The following is a description of a gene set: Human Gene Set: FOURATI_BLOOD_TWINRIX_AGE_25_83YO_RESPONDERS_VS_POOR_RESPONDERS_0DY_DN from publication Fourati S, Cristescu R, Loboda A, Talla A, Filali A, Railkar R, Schaeffer AK, Favre D, Gagnon D, Peretz Y, Wang IM, Beals CR, Casimiro DR, Carayannopoulos LN, Sékaly RP (PMID 26742691) species: Homo sapiens Genes down-regulated in blood responders vs poor responders in adults (25-83) (responders) after exposure to Twinrix, time point 0D Aging is associated with hyporesponse to vaccination, whose mechanisms remain unclear. In this study hepatitis B virus (HBV)-naive older adults received three vaccines, including one against HBV. Here we show, using transcriptional and cytometric profiling of whole blood collected before vaccination, that heightened expression of genes that augment B-cell responses and higher memory B-cell frequencies correlate with stronger responses to HBV vaccine. In contrast, higher levels of inflammatory response transcripts and increased frequencies of pro-inflammatory innate cells correlate with weaker responses to this vaccine. Increased numbers of erythrocytes and the haem-induced response also correlate with poor response to the HBV vaccine. A transcriptomics-based pre-vaccination predictor of response to HBV vaccine is built and validated in distinct sets of older adults. This moderately accurate (area under the curve ~65%) but robust signature is supported by flow cytometry and cytokine profiling. This study is the first that identifies baseline predictors and mechanisms of response to the HBV vaccine., and this is the list of marker genes: CRCP, DDI1, KPNA6, CDCA8, RNF112, CYP2C8, PARP9, TPP1, ASCL2, NSD3, ITGA2B, KXD1, LOXL4, NUDT16-DT (NCBI Gene Id 339874), FKBP9, TBCD, TCERG1L, HS2ST1, REEP3, ZFHX3, OASL, TNNI2, FMNL1-DT, BEND7, CAMP, CD14, TPSD1, MT2A, GNAT1, KDM5D, TTTY7B, CAVIN3, HNMT, NUP93, KCNQ1, PGBD2, GNG4, LINC01503, IFI44L (NCBI Gene Id 10964), WNT5B, CEP63, AGFG1, RBMY1A1, TTLL3 (NCBI Gene Id 26140), WWC2 (WW and C2 domain containing 2), VPS53, TNFSF10, SCD, TXLNGY, ATP8B3, DGKG, LINC01168, LRRC75B, VCX3A, CDH17, GFER, CRISP3, TNPO1 (NCBI Gene Id 3842), KIF18B, TRIM21, HPR, IFI16, PIWIL2, VCX, AAMDC, TTTY1, PPARA, HSPA1B, TONSL, HOXB-AS3, FGF18, MAP2K6, TGIF2LX, ANXA8L1, CIMAP1B, CTTNBP2NL, FAM114A1, PLB1, ELOVL3, VEGFC, BEAN1, CFAP46, NUMA1, LINGO2, ADGRF3, DCLRE1C, NETO1, PTX3, ALYREF, PLAAT5, FSTL3, PDE12, TPM1, ABHD2, STBD1, RBM47, RECK, MED29, ZMYND10, DMXL2, RRBP1, TDRD9, GNA14, GLB1L3, TTTY1B, NOTCH2NLA, IFIT3, SLC35A2, RFTN1, MICAL2, SRRM2, NISCH, COL2A1, LOXL3, RABL6, ETV6, CTSB, RHOU, PROB1, H2BW1, DYNLT2B, RCOR3, DLEU7, CORO2A, HPX, B4GALNT2, CTSG, YWHAE, DDX6, SH3RF1, KCNJ2, TRPM2, ZNF516, RO60, CGAS, SLPI, IFI27 (interferon alpha inducible protein 27), STMN1, ZFP91-CNTF, GPR84, NCLN, FXYD6, LYPD4, IKBKG, EPHB2, GPD2, PAQR5, PCLO, LDLRAD3, FGG, SP110, DLGAP5 (DLG associated protein 5), SAP30, FGD4, PRR11, ITGB3 (NCBI Gene Id 3690), WBP2NL, SCG3, POMC, PYGB, ATF7, TPCN2, NT5DC4, HBZ, KRT73, CCDC149 (coiled-coil domain containing 149), NEK3 (NIMA related kinase 3), ST8SIA5, AGRN, TTTY14, NCBP3, AKR1B15, SENP5, FCER1G, H4C9 (NCBI Gene Id 8294), SNORD62B, AFMID, XKRY, RBPJ, TTTY2, CTNNBIP1, MX1, COL6A2, NPRL3, PGPEP1, GAB1, ASRGL1, EPS8L1, ZBP1, RNASE3, KAT6A, TCERG1, TMEM8B, CABIN1, SHROOM3, TKT, ANOS1, CDT1, CD163 (NCBI Gene Id 9332), MYB, C22orf23, PRRC2C, CCNB2, LRATD1, SLC46A1, SIRT6, ROCK2, AGTPBP1, TNFSF13B, ITGA9, UBR4, DAGLB, LRRC71 (leucine rich repeat containing 71), BAK1, HEATR3, OAS1, LATS2, SNAP23, CTNNA1, SLC32A1, FCAR, SLC17A5, ZFP91, TJP2, LINC00901, SERINC2, DLG5, PGA4, MMP11, ANKRD11, SPATA31C1, URB1, MEAK7, MET, H2AZ2, PML, CASP10, PPP4R2, FGD6, EVX1, LINC01270, PRKD1, GRK3, DDX3Y, RPL7L1, NTNG2, CENPE, TSBP1, ISG15, NBPF10, LGALS12, AZU1 (azurocidin 1), OSGIN1, DEFA4, UNC93B1, LINC00588, CAPN1 (calpain 1), SLC39A7, CAPG, SCRG1, SPATA31C2, MEG3, UQCRQ, GNA11, ACADS, CYRIA, AIF1, ARF5, CFAP73 (cilia and flagella associated protein 73), UNKL, GLB1L, HCN2, VCAN, FCN1, ABL2, SCRT1, LRSAM1, FOLR2, SLC6A5, CUX1, SCARB2, CASQ1, TPSAB1, EMC9, FAM95B1, LGALS3BP, HP, CILK1, SLC22A18AS, LRRK1, PRR27, COL11A2, SYT5, JPH4, TLK2 (NCBI Gene Id 11011), HTRA1, NUMBL, TRIM14, C3AR1, NFIC, SLC27A4 (NCBI Gene Id 9176), FAM3B, CDC42BPA, RPS4Y1, ARSA, STK36, MAP3K20, RBMY1B, MX2, SLC9B1, PCA3, NEURL1, NR2F2, TRAPPC14, ZNF704, RERE, SNORD9, SF3B1, UBE2C, VHL, OR52E8, TADA2A, SPIRE2, CLTCL1, XKRYP7, H4C1, MMP8, CD300E, BOD1L1, HPGDS, NHSL1-AS1, TNRC18, KIF9, RBMY1E, MEX3C, TEP1, H3C13, IL34, ADAM17, TSHZ3, TM7SF3 (NCBI Gene Id 51768), NBPF15, ZEB2, MAPK14, EPB41L1-AS1, ADAMTSL2, PSORS1C3, MPO, OPLAH, SCCPDH, BPI, DEFA1 (NCBI Gene Id 504182), CFAP119, H3C15, GPN2, TGIF2LY, NR6A1, NUDT3, PIK3AP1, TPMT, ATP5MF, PLSCR1, TBC1D16, FUOM, RRAGD, PALLD, COG4, BTN3A1 (NCBI Gene Id 11119), MTCL1, RNF208 (ring finger protein 208), PAQR6, BAZ2B, LFNG, CSNK1D, POLR3K, IRF7, THBS1, NIBAN1, SPATA41, PFKFB3, ANGPT1, CYTOR, HLA-DRB4, P2RY2, GPR151, ATF6, PLCE1, APP, IGF1R, REC8, NECTIN1, CD109, SPATA2L, AGMO, CRHBP, LINC02649, HLA-A, HLA-DQA1, PNPLA1, PLIN5, HGF, RNF32-DT, ABCC6, RPS4Y2, MMP19, RALGPS2-AS1, ADGRE2, OR6C1, TNNT3, CD63, ERBB2, OTX1, CHIT1, LINC00900, NRARP, ZNF106, SIN3B, NUDT12, RSPH9, MYCL, SLC36A1, PTPRZ1, FUCA2, CAD, RING1, SLC5A12, LRMDA, PPFIA1, COL4A1 (collagen type IV alpha 1 chain), VCX3B, DHRS4L2, TP53I3, MIR4435-2HG, APOL6, NMNAT2, IFI44 (NCBI Gene Id 10561), DNAH12, BBS7, S100A4, PCBD2, ABCB5, MROH7-TTC4, KIAA2013, TYMP, BPESC1, KCTD20, USF1, GCM1, NUBP2, H3C14, CHCHD2, SORT1, KLK10, KLHL10, KAAG1, PAWR, EXOSC3, ART1, TLE6, HEATR5A, ARPC4-TTLL3, KIF5B, NAAA, EPB41L3, NDUFA4L2, STK11IP, GPR107, EPB41L4A, ARL11, CEACAM8, MKI67, OLAH, APLP2, GLMP, HELZ2 (helicase with zinc finger 2), SYNE4, UCP3, LMOD3, TMSB4Y, IRF9, RUSC2, TCN2, SMG5 (SMG5 nonsense mediated mRNA decay factor), ATP5MF-PTCD1, TARM1, ZFYVE1, ARHGEF10L, OR51T1, BRD7, TIMP3, NBR1, CEACAM21, CNRIP1, NMB (NCBI Gene Id 4828), YIPF1, LINC02724, MROH7, HCN3, SLC25A18, TK2, INO80 (INO80 complex ATPase subunit), BUB1B, FAH (fumarylacetoacetate hydrolase), IFI6, SOS2 (SOS Ras/Rho guanine nucleotide exchange factor 2), SUPT6H, STAC3, MT1E, PSAP, MRPS12, PGA3 (NCBI Gene Id 643834), EIF1AY, PIK3R3, APOA1, AFDN, NEXN-AS1, SERPINB2, PINLYP (NCBI Gene Id 390940), DUSP7, SKA1, PLCB3, ANXA5, ESS2, ANO10, ADAM12, RSAD2, RSPH3, MBOAT2, SNORD62A, UTY, CMIP, SYN2, NBPF14, TRIM66, LILRB1, FLYWCH2, ZFY, UNC45A, TPSB2, SULT4A1, GCNT2, SIGLEC1, TNFAIP2, LINC00301, DLG4, EIF2B3, CEACAM6, JDP2, HAND2-AS1, RPS10-NUDT3, SPINK7, DEFA1B, SSH3, TIRAP, CD177 (CD177 molecule), IL5RA, NAGK, FGF1, AGPS, TPPP, KIAA0825, KPNB1, CBX2, MAFG, CHD7, ATP8A2, KISS1R, STRIP2 (striatin interacting protein 2), AKR7A3 (aldo-keto reductase family 7 member A3), RTL5, KLK15, FRMD7, DUSP3, AFF1, KRT37, GSEC, TTTY2B (testis expressed transcript, Y-linked 2B), INPPL1, MYO10, ANKRD50, LAS1L, PRPS1L1, CLEC7A, RUBCN, OLFM4, CARD16, HAUS2, TTTY20, SPNS3, KIR3DL1, PRTN3, TROAP, HEATR1, MAP3K6, PTN, RBM12B-AS1, LZTS3, SART1, MTNR1A, SLC22A18, UNC5A, KTN1, PLTP, SLC2A14, ANXA8, ITIH3, SLC27A3, ENKD1, XPR1, RNF20, TMEM44, TMED6 (NCBI Gene Id 146456), NLN, NR0B1, RBMY1D, TNPO3, LAYN, EGF, MRE11, LRP1, CA14, MND1, LACC1, CALML4 (calmodulin like 4), MYBPC3, LINC01305, PRSS36, OTUD4, GTF3C2, LILRA6, SEPTIN3, LCN2, WRAP53, SLC6A8, CPLANE1, USP9Y, ARHGEF37, SELENOS, PTPN14, ELANE, BAZ2A, DLEU2, RIN1, CC2D2B, TMEM53, ZBTB47, LARP4B, S100A13, OAS3, TTTY8B, ADCY9, ZFY-AS1, INF2, C7orf50, PPARG, TTTY8, DISP3, TFIP11, AGBL1 (AGBL carboxypeptidase 1), TCN1, AADACL3, GBA1, TAOK2, LINC01686, GM2A, FCHSD1, SERPINB6, UBE2L3, SAMD4A, TMEM91, RAB20, TRIM50, TOP2A, MAD2L1, CDC42EP4, KLHDC9, ANAPC11, TTTY7, OLFML2B (olfactomedin like 2B), PGA5 (pepsinogen A5), CACUL1, NCKAP1L, ATP11A-AS1, TTTY3B, SPECC1, TRIP10, CBS, RBP7, CD101, LTF, USP24, BAHCC1, PRDM7, TTTY10, SLC20A2, RREB1, STAT1, TLE4, HS3ST5, VWC2, AGPAT4, IFITM3, ZNF829, TTTY3, IGSF21, PIK3R6, MKKS, PIP4K2B, LILRB4, SZT2, RAD51C, SYDE2, HAUS6, RAD51, MVB12B, CYBB, C6orf136, NECAB1, DEFA3, INSR, ALDH3B1, SNX27, ZC3H13, NLRP3, RETN, PLXNB3, FYTTD1 (forty-two-three domain containing 1), KIAA0319L, AFF2, SLC26A3, SPNS1, SFXN5, ADAP2, KCNQ2, RELL1, CLPS, DENND1A, ZNF562, TENT5A, ADORA3, ERMAP, THRA, NOTCH2 (NCBI Gene Id 55574), CDX1, ST6GALNAC4